The following is a description of a gene set: species: Homo sapiens Genes whose expression significantly and negatively correlated with oligodendrocyte density in layer VI of BA9 brain region in patients with bipolar disorder. Cytoarchitectural abnormalities have been described in the prefrontal cortex of subjects with schizophrenia, bipolar disorder and depression. However, little is known about the gene expression profiles associated with these abnormalities. Genome-wide expression profiling technology provides an unbiased approach to identifying candidate genes and biological processes that may be associated with complex biological traits such as cytoarchitecture. In this study, we explored expression profiles associated with the abnormalities by using publicly available microarray metadata and cytoarchitectural data from post-mortem samples of the frontal cortex from 54 subjects (schizophrenia, n=14; bipolar disorder, n=13; depression, n=12 and controls n=15). Correlation analysis between genome-wide expression levels and cytoarchitectural traits revealed that genes were significantly correlated with a decrease in the number of perineuronal oligodendrocytes across all subjects. A total of genes were significantly correlated with a decrease in density of calbindin-positive interneurons across all subjects. Multiple biological processes including cellular metabolism, central nervous system development, cell motility and programmed cell death were significantly overrepresented in both correlated gene lists. These findings may provide novel insights into the molecular mechanisms that underlie the cytoarchitectural abnormalities of perineuronal oligodendrocytes and calbindin-containing GABAergic interneurons in the prefrontal cortex of the major psychiatric disorders. Human Gene Set: KIM_BIPOLAR_DISORDER_OLIGODENDROCYTE_DENSITY_CORR_DN from publication Kim S, Webster MJ (PMID 18762803), and this is the list of marker genes: IFNA6, SLC5A2, EFNA5, MME, RAPGEF3, SBNO2, CADM4 (cell adhesion molecule 4), BMP4 (bone morphogenetic protein 4), NCR3, ALX1, CYP2A13, CSRP3, PFKFB4, CGA, CDX1, APOC3, TRPV6, DBH, TNF, CCL7, H1-1, LTA, CRISP3, COL8A1, CDX2, ICOS, MSH5, UPK3A, GPR18, IL5, SLC22A13, CAMP, ALDH3B2, IL3, ZNF157, SERPINE1, DTX2, CDKL1, GYPE, CCIN, REN, CRHR2, EPHA2, S100A8, HRK, CCL23, WNT11, MAFK, P2RY11, LFNG, PRSS8, MMP11, B3GALT5, GPR39, GRAP2, FUT7, IL1RAP, PITX3, HOXC5, FSHR, PAX7, ALPK3, PYY, CDSN, MSC, FBP2, CYP2C18, CCL1, PMCH, XRCC3, TOP2A, ORC1, CRYBB3, LHCGR, HSD11B2, FGA, LHB, PLA2G1B, KISS1, SLC7A2, SCEL, SULT2B1, LINC00837, ESR1, GABRA3, PMM2, CD72